Given this list of marker genes PKD2L1, PRKCSH, LRRC26, PYCARD, ACTN3, SCN1B, SCN3B, AKAP9, ANK1, SLC8A1, FKBP1B, KCNAB1, PLN, PIRT, FMR1, GOPC, PRNP, PGK1, CALM3, BAK1, ID2, STK39, SRC, YWHAH, CBARP, LYN, KCNC2, FXYD1, KCNE4, CASR, LRRC52, FGF13, KCNJ11, ABCC9, TRDN, GRINA, LRRK2, WWP2, TSPO, TCAF1, LRRC55, DIAPH1, CALM1, PDE4B, FKBP1A, FGF12, ABCC8, CAMK2D, SCN10A, ATP1A1 (ATPase Na+/K+ transporting subunit alpha 1), SCN4B, PPP2CB, HOMER1, YES1, PKP2, VDAC1, RANGRF, TF, FLNA, STX1A, NEDD4L, ANK3, DLG1, CALM2, LRRC38, YWHAQ, HSP90AA1, PPP1R9B, TCAF2, CABP4, YWHAE, STAC, CNTNAP2, AKAP6, CTNNB1, KCNG4, KCNIP2, CAV1, TRAPPC2, REM1, RIMS3, KCNC1 (NCBI Gene Id 3746), SMIM26, NOS1, KCNE2, SCN7A, PHPT1, SCN5A, KCNIP1, ASPH, MTOR, ATP2A2, KCNE5, GPD1L, PDE4D, USP10, KCNB1, PANX1, KCNAB3, ITPR2, CDH5, S100A10, SRI, HAP1, FHL1, KCNE3, OXSR1 (NCBI Gene Id 9943), SNTA1, ANK2, SLC5A3, BAG2, ATP2A3 (ATPase sarcoplasmic/endoplasmic reticulum Ca2+ transporting 3), ACTN1, TRPC1, WNK3, RNF207, RIMS4, CAV3, PACS1, CIB1, MASTL, YWHAZ, AP2M1, KCNE1, KCNH5, GSTM2, FYN, ACTN4, DPP10, HERPUD1, ACTN2, KCNAB2, NEDD4, HRC, CHERP, KCNQ1, HTT, PKD1, TMEM74, PACS2, PKD2, RIMS2, TCAP, CRBN, here is a description of the gene set: Binding to a transmembrane transporter, a protein or protein complex that enables the transfer of a substance, usually a specific substance or a group of related substances, from one side of a membrane to the other. Human Gene Set: GOMF_TRANSMEMBRANE_TRANSPORTER_BINDING species: Homo sapiens